Given this list of marker genes PHF23, ADGRG3, CAND2, SLC35B4, BAG5, RAE1, METTL23, CFAP298, ATF1, TNNT1, LCK, TMEM164 (transmembrane protein 164), SCAMP3, GPS1, MUS81, IQGAP2, N4BP2, CRY1, OXA1L, CD8A, ZC3HC1 (NCBI Gene Id 51530), MAP3K3, ARFIP2, SLC16A5, CCR4, MTA3, CXXC1, GIMAP1, FLT3LG, IPP, CCDC125, RCL1, SMARCAL1, SUSD1, GSKIP, RNPS1, JMJD8, METTL2B, MTHFD1L, DRG1, GEMIN8, FASN, DNTTIP1, MAF1, PYCR2, DERA, TTC19, NOL11 (nucleolar protein 11), RAB35, ZNF277, ZAP70, BABAM2, GART, EGR2, MED27, DNAJB1, SIT1, KBTBD4, EML2, ZCCHC12, RAB37, PIAS2, YME1L1, ACAA2, LYRM9, ARHGAP1, NT5C3B, RUNDC3B, LETM1, GATD1 (NCBI Gene Id 347862), TRAPPC12, ERC1, CDC25A, DOCK8, TUBA4A, CEP57L1, SLC35F2, DDX18, HAUS7, PADI3, CD160, GTPBP3, TRAF4, KRI1, GEMIN5, PPP2R1B, ENTREP3, SKAP1, HCLS1, ABHD8, ZC4H2, BTF3L4, GZMA (NCBI Gene Id 3001), RCCD1, GSTK1, ANP32E, C8orf58, TMLHE, LRRC28, ACYP1, ARHGEF6, PAIP2, RASGRP2, FERMT3, ICAM2 (NCBI Gene Id 3384), PJA1, KAT5, NME7, TXNIP, SURF6, RPF1, CELF5, KLHL6, FBXO9, STK24, TMEM108, ARHGAP30, GTPBP8, BDH1, GLMN, CD8B, PRMT5, PES1, EPHB6, ITM2A (integral membrane protein 2A), BAIAP3, LEPROTL1, CARD6, PRKAB1, GIMAP6, BORCS8, PRF1, GOT1, RHOH, LTA4H, AP3B2 (adaptor related protein complex 3 subunit beta 2), CD200R1, LY9, KLF13, CTSW, CCR9, PLD3, TMEM60, SELL, ABCB9, TXK, ZBTB25, GPR18, EPHX1, RPA1, PIK3IP1, NT5C2, CPA3, TBXA2R, STAP1, INPP5E, RGS14, CD96, KAT8, ITPRIP, LIME1, RAD52, SFXN2, UNC5CL, XRCC6, CD37, MYNN, ARHGDIB, PITPNA, B3GALT4, ARL16, DZIP1, COL23A1, PRKCH, KLK8, PGLYRP2 (peptidoglycan recognition protein 2), WRAP73, COX18 (NCBI Gene Id 285521), RABGGTA, POLR1B, CD247, QSOX1, THEMIS, CASP6, PIK3CG, VPS26B, UBE2D3, UROD (NCBI Gene Id 7389), XPO4 (NCBI Gene Id 64328), CAP2, UBE2Q1, RSU1, RAMAC, DYNC1LI1, UBASH3A, USP42, CD3D, CCDC30, DNAJC19, here is a description of the gene set: studied in species Homo sapiens Genes down-regulated in polymorphonuclear leukocytes (9h): treated by heat killed HC60 cell (promyelocytic leukemia) lysate versus A. phagocytophilum infection. from publication Borjesson DL, Kobayashi SD, Whitney AR, Voyich JM, Argue CM, Deleo FR (PMID 15879137) Polymorphonuclear leukocytes (PMNs) were obtained from healthy individuals in accordance with protocols approved by the Institutional Review Board for Human Subjects at the University of Minnesota and the National Institute of Allergy and Infectious Diseases. PMNs (107) were combined on ice with live S. aureus (108) or with live or heat-killed A. phagocytophilum (bacteria isolated from 5x106 infected HL60 cells for a ratio of 1 infected HL60 cell: 2 PMNs, ~ 5-20 A. phagocytophilum: PMN) in wells of a 12-well tissue culture plate (pre-coated with 20% autologous normal human serum). Unstimulated control assays received either buffer (for S. aureus comparisons) or clarified HL60 lysate (for A. phagocytophilum comparisons). Plates were centrifuged at 350 x g for 8 min at 4oC to synchronize phagocytosis and incubated at 37 deg. C in a CO2 incubator for the indicated times. At the indicated times, tissue culture medium was aspirated from the plate and PMNs were lysed directly with RLT buffer (Qiagen, Valencia, CA). Purification of PMN RNA and subsequent preparation of labeled cRNA target was performed as described in Methods. Labeling of samples, hybridization of cRNA with HU133A oligonucleotide arrays (Affymetrix, Santa Clara, CA), and scanning were performed according to standard Affymetrix protocols ( http://www.affymetrix.com/pdf/expression_manual.pdf ). Experiments were performed in triplicate, using PMNs from three healthy individuals for each treatment. Human Gene Set: GSE2405_HEAT_KILLED_LYSATE_VS_LIVE_A_PHAGOCYTOPHILUM_STIM_NEUTROPHIL_9H_DN